The following is a description of a gene set: studied in species Homo sapiens Human Gene Set: REACTOME_CO_INHIBITION_BY_BTLA Co-inhibition by BTLA, and this is the list of marker genes: TNFRSF14, GRB2, PTPN6, PTPN11, BTLA